Given this list of marker genes Vopp1, Uhrf1, Ybx3, Avl9, Tcaf1, Gbp2, Dse, Macf1, Cnot6l, Uchl3, Plekha1, Spag9, Ikzf4, Gng5, Hmgcr, Fnbp1l, Prpf31, Ahnak, Mpc1, Palld, Slc25a29, Bcl2a1a, Cmpk1, Serpinb6a, Nrp1, Cyb5a, Itm2b, Srsf10 (NCBI Gene Id 14105), Ptpn9, Irgm2, Foxn3, Map1lc3b, Lgals1, Gpx1, Phkg2, Bcl2a1b, Map4, Tle3, Ywhaz, Foxn2, Batf3, Pdcd1lg2, Fabp5, Anxa5, S100a10, Adgrg6, Glipr2, Tcaf2, Pkn1, Nectin2, Rsu1, Mfhas1, Fhip1a, Mbp, Capg, Anapc2, Cytip, Etnk1, Rel, Prdm1, Rai14, Slfn2, Cdkn1a, Malt1, Eif3a, Oasl2, Tes, Litaf, Hnrnpk, Hivep1, Phlda3, Calm3, Rhoa, S100a11, Rfk, Echdc1, Trip12, Cyth3, Huwe1, Zfp263, Myh9, Cltc, Ly75, Bcl2a1d, Pnkd, Slc33a1, Klf13, Cdk6, Psen2, Necap2, Ywhah, Atp6v0a1, Tle5, Rbpj, Taldo1, Ocln, Ndrg1, Rab14, Cfl1, Nfil3, Ctsz, Pik3r5, Nup88, Tkt, C1qbp, Noct, Rap2b, Ktn1, Prps1, Anxa3, Mob3a, Gtf2b, Cd86, Ikbkb, Diaph1, Gpr141, Tagln2, Cacnb3, Fgl2, Cish, Plk2, Esyt2, Serpina3g, Lmo2, Acvr1 (NCBI Gene Id 11478), Kras, Fkbp1a, Igtp (NCBI Gene Id 16145), Pnp, Il10ra, Nr4a3, Pacsin2, Vim, Gnai2, Rap1b, Kif1b, Cox6a1, Pde1b, Itgb1, Cd274, Csf2rb, Cmtm6 (CKLF-like MARVEL transmembrane domain containing 6), Ttc39b, Ifi35, Scn3a, Gpbp1 (GC-rich promoter binding protein 1), Mmp23, Rabgap1l, Cd48, Lasp1, Tnfrsf4, Glycam1, Cracr2b, Olfm1, Smap2, Ssh1, Ap2s1, C1d, H1f10, Tmem70, Krcc1, Wipf1, Tomm22, Tpm4, Serp1, Samhd1, Wars1, Mylk, St8sia4, Ptpn1, Mcl1, Pkib, Nap1l1, Ncoa3, Rap2a, Suv39h2, Irf5, Cst3, Kdm6a, Ggta1, Tec, Rpain, Rnf149, Rer1, Elf2, Auh, Ptger4, Lgals3, Atg2a, Mapkap1, Plek2, Cox17, Pirb, Ctss, Vdr, Pdlim5, Atp6v1g1 (ATPase, H+ transporting, lysosomal V1 subunit G1), Pcyt1a, Snrpb, Srsf6, Jpt1, Trp53bp2, P2ry10 (NCBI Gene Id 78826), C1qtnf12, Cmtm7, Tbc1d4, Napsa, Ppig, Acsl5, Tmsb10, Tax1bp3, Galnt7, Orai1, Bcl10, Gclc, Diablo (NCBI Gene Id 76700), Socs2, Jak2 (Janus kinase 2), Lpl, Retreg1, Atrx, Nudt17, Ikzf1, Ntmt1, Snd1, Xbp1, Bcl7c, Myadm, Mier3, Fcgrt, Pfn1, Rac3, Csnk1d, Ehd1, Samd1, Ppp2r5b, Snupn, Gsn, Gnb4, Ppdpf, App, Agps, Cyfip1, Tmcc1, Plgrkt, Vps35, Sft2d2 (SFT2 domain containing 2), Syngr2, Tnfrsf11a, Adra1a, Elmo1, Dek, Grk2, Zfand6, Mdfic, Ddx39a, Vps29, Cyrib, Macroh2a1, Nt5c, Traf5, Eid2, Washc2, Washc4, Rcl1, Ccl22, Lrrc8c, Klf6, Rabep1, Dapk1, Sh2b3, Socs1, Gbp5, Pim1 (proviral integration site 1), Fchsd2, Cox6b1, Rab30, Gm266, Crem, Bach1, Trim14, Prkcd, Large1 (NCBI Gene Id 17871), Jaml, Slc7a5, Nrp2, Bcl2l11, Fyco1 (FYVE and coiled-coil domain containing 1), Fscn1, Set, Ctsc, Iqgap1, Lima1, Scimp, Ccl17 (NCBI Gene Id 20295), Sipa1l3, Psmd11, Snx8, Mir155hg, Tab2, Atp5pf, Uap1, Cbl, Ehd4, Metrnl, Adcy6, Sh3bgrl, Crip2 (NCBI Gene Id 97790), Uri1, Cd302, Fam133b, Adprh, St6gal1 (beta galactoside alpha 2,6 sialyltransferase 1), Yeats4, Chd7, Rhoc, Ddx54, Ubxn2a, Ralb, Susd6, Khdrbs1, Afdn, Myl12b (myosin, light chain 12B, regulatory), Nckap1l, Ramac, Relt, Orai3, Uqcr10, Nfkb1, Dock10, Coro2a, Sphk1, here is a description of the gene set: from publication Cui A, Huang T, Li S, Ma A, Pérez JL, Sander C, Keskin DB, Wu CJ, Fraenkel E, Hacohen N (PMID 38057668) Cytokines mediate cell-cell communication in the immune system and represent important therapeutic targets. A myriad of studies have highlighted their central role in immune function, yet we lack a global view of the cellular responses of each immune cell type to each cytokine. To address this gap, the authors created the Immune Dictionary, a compendium of single-cell transcriptomic profiles of more than 17 immune cell types in response to each of 86 cytokines (>1,400 cytokine-cell type combinations) in mouse lymph nodes in vivo. A cytokine-centric view of the dictionary revealed that most cytokines induce highly cell-type-specific responses. For example, the inflammatory cytokine interleukin-1β induces distinct gene programmes in almost every cell type. A cell-type-centric view of the dictionary identified more than 66 cytokine-driven cellular polarization states across immune cell types, including previously uncharacterized states such as an interleukin-18-induced polyfunctional natural killer cell state. Mouse Gene Set: CUI_LANGERHANS_GM_CSF_RESPONSE_UP Genes positively differentially expressed in cell type: Langerhans upon treatment with cytokine: GM-CSF in mouse lymph nodes in vivo. studied in species Mus musculus